Given this list of marker genes Slc6a3, Aph1c, Ctnna2, Grin3a, Drd2, Fabp7, Mdga1, Grid2, Dbn1, Drd3, Pten, Dvl1, Aph1b, Chd8, Drd4, Bace1 (beta-site APP cleaving enzyme 1), Drd1, Ucn, Nrxn1, Grin1, Nlgn3, Adora2a, here is a description of the gene set: studied in species Mus musculus The process in which a startle magnitude is reduced when the startling stimulus is preceded by a low-intensity prepulse. Mouse Gene Set: GOBP_PREPULSE_INHIBITION